Given this list of marker genes RPL13, COL2A1, COL9A1, COL11A1, UFSP2, CDC6, ADAMTSL2, RNU4ATAC, PEX5, TRPV4, here is a description of the gene set: Human Gene Set: HP_IRREGULAR_FEMORAL_EPIPHYSIS Irregular femoral epiphysis studied in species Homo sapiens